The following is a description of a gene set: The directed movement of substances into, out of or within a lysosome. Human Gene Set: GOBP_LYSOSOMAL_TRANSPORT studied in species Homo sapiens, and this is the list of marker genes: CCDC91, LAPTM5, GRN, VCP, PLEKHF2, HSPA1A, CLU, SORL1, KIF13A, NCOA4, SLC30A4, CHMP1B, VPS41, AP3D1, AP4M1, RILP, PIK3C3, NAGPA (NCBI Gene Id 51172), VPS4A, CHMP2B, LRP1, VPS35, CHMP7, VAMP7, CDX2, MFSD1 (NCBI Gene Id 64747), VPS51, RHOB, AP1G1, PLEKHM1, LYST, CHMP3, PLEKHF1, LAMP2, M6PR, PCSK9, LIPA, C9orf72, CHMP4C, ATG14, TPCN2, BECN2, BIN1, VPS18, CHMP5, GNPTAB, CHMP4A (NCBI Gene Id 338010), UBXN6, HOOK1, ANKFY1, NPC1, VPS33B, PCDHGA3, AKTIP, PINK1, CHMP6, RAB7A, GPRASP1, GAK, RUFY4, LAMP1, VPS39, ADRB2, VPS54, HSPA8, RBSN, VPS53, GNPTG, AP3B1, USE1, HGS, MGRN1, SNX27, ARL8B, SLC48A1, SCYL2, SCARB2, PSAP, PIK3R4, NDP, IGF2R, FHIP1B, VIPAS39, PRKN, SLC30A2, TGFBRAP1, VPS4B, SNX16, SLC17A9, GCC2, VPS11, SLC30A3, SNAPIN, CHMP2A, SORT1, MVB12A, RAB7B (RAB7B, member RAS oncogene family), DENND3, TMEM106B, CHMP1A, HMGXB4, TRAK1, EPG5, VPS33A, RAB12, HOOK2 (NCBI Gene Id 29911), ATP13A2, TRAK2, UEVLD, HOOK3, VPS16, TSG101, ALS2, WASH3P (WASP family homolog 3, pseudogene), VPS52, ZFYVE16, CLN3, HGSNAT, AP3M1, LRRK2, MTM1, CHMP4B, SPTBN5, CHMP4BP1, EHD3, ARSB, NEDD4, DTX3L (NCBI Gene Id 151636), LYSET, GGA3, BECN1